The following is a description of a gene set: species: Mus musculus Mouse Gene Set: chr7D2, and this is the list of marker genes: Gm15504, Gm44705, Gm35040, Rhcg, Rlbp1, Gm16017, Mir9-3, Gm23239, 4921513I08Rik, Ngrn, 2900037B21Rik, Vps33b, Det1, Gm15544 (predicted gene 15544), Furin (furin, paired basic amino acid cleaving enzyme), Idh2, Mrpl46, Wdr93, Mfge8, Gm39038, Mesp2, Anpep, Unc45a, Blm, Hddc3, Prc1, 5430400D12Rik, Gm26633, Pex11a, Arpin, Cib1, 9330171B17Rik, Hapln3, Ndufab1-ps, Rccd1, Plin1, Acan, Gm31510, Ttll13, A330074H02Rik (NCBI Gene Id 402758), Ap3s2, Gm39041, Kif7, Zfp710, Abhd2, Gm45202, 5330411O13Rik, Mir9-3hg, Gm9885, Sema4b, Ticrr, Gm21057, Ntrk3, Fanci, 1700011D18Rik, Gm10616, Gdpgp1, Aen, Mir7-2, Mesp1, Mrps11, Isg20, Fes, Gm44851, Polg, Man2a2